The following is a description of a gene set: from publication Chen Y, Wang X (PMID 31504780) species: Homo sapiens Human Gene Set: MIR6824_3P Genes predicted to be targets of miRBase v22 microRNA hsa-miR-6824-3p in miRDB v6.0 with MirTarget v4 prediction scores > 80 (high confidence targets)., and this is the list of marker genes: NR2C2, INAFM2, HDHD2, TRABD2B, WDFY1, MGA, MSR1, GRM1, PCNX1, KLHL9 (kelch like family member 9), FAM124A, MRFAP1, MTA3, SLC38A2, ACSL1, DDI2, MLXIP, C22orf46P, RNF185, KAT6A, ID1 (NCBI Gene Id 96820), GRIK3, AQP9, G6PC2, ZNF135, SHC1, BHMT2, DNAAF6, ZNF268, SLC35F3, GTF2A2, DES, PALM, EXT1, FNDC3A (NCBI Gene Id 22862), TMEM60 (transmembrane protein 60), ELMO2, VXN, MRAS, PDPK1, UBXN10, TMTC2, PPP2R5E, SNX30, ZDHHC11, ZFP1, ITGA5, FCHO2, PPFIBP1, PRMT8, NRAS, PRKCA, CLCN5, CHCHD4, STAU1, PARP2, ZNF426, GPD2, HECTD3, BBX, LAIR1, ODR4, FGF11, EZH1, RUNDC3B, AP5M1, ROR1, PRICKLE2, NRP2, SLC25A23, SLC66A3, MBD5, TOR1AIP1, ETS1, BAZ2B, ZNF655, WDFY2, KCNIP2, DACH1, ZBED1, RTL5, SHISA7 (shisa family member 7), AAK1, USP3, GTF3C4, RNF2, ARID5B, CHCHD3, RALGAPA2, RUSF1, NHERF2, UBE2D1, PTK2, MSI2, BTBD7, EPB41L1, KCNRG, ZNF544, NDN, ZNF562, LSM11, CAMTA1, JAKMIP3, C18orf63 (chromosome 18 open reading frame 63), CELSR3, LUZP1, EPHB3, PDK3, DYNLL1, PTBP1, ZNF365